Given this list of marker genes RASGRF2, VCPIP1, GEMIN2, E2F2, RASSF3, TRIM71, NT5DC1 (NCBI Gene Id 84571), CHTF8, MAP3K10, TMEM135, RREB1, FBXO42, SLC26A6, RASGRF1, FBXW4, PLEKHM3, RAP1A, FIBP, ZSWIM4, CBLL1, MAP3K11, SLC6A17, MAP3K13, REST, FAM169BP (family with sequence similarity 169 member B, pseudogene), NHSL3, NCAN, MFSD13A, GTF3C3, BTG2, IER3IP1, RORA, DUS1L, TTC7A, DPH2, JADE2, MAPRE2, NCOR2, FAM118A, GGA2, DTX4, AMIGO2, RPL28, SEL1L, TOMM40 (translocase of outer mitochondrial membrane 40), BAG4, EIF2B5, ANKRD50, MKNK2, NHERF4 (NCBI Gene Id 79849), FRMD5, TMEM168, EIF4EBP1, SEMA4F, PHACTR3, SRF, SPTB, LACTB, KLF13, LRRC8B, ANAPC16, CDR2L, CDH5, MEMO1, MAP3K9, KCTD15, VTCN1, LRRC10B, HIF1AN, ZNRF3, PPP4R3A, PRSS35, LRP4, SLC16A6, PADI2, BCL2L14, TMPRSS13, NCKAP5L, VPS36, NKAPD1, CRB2, DOCK3, SARM1, SCARB1, LBH, HOMEZ, TNFAIP3, RBAK, RETREG3, ZNF691, VPS4B, KCNS3, UBE2G1, USP2, SAMD10, EPO, OLFML2A, ADAM28, GCNT1, NDUFA2, FUT4, RABEP2, KMT5C, ESRRA, UBR7, GALNT14, BAP1, SEC14L2, MXD4, M6PR, RABL6, ITGA8, NECAB3, PCDH7, LIN28A, SLC7A1, TSEN54, LFNG, GOLGA5, RHOQ, RFXANK, SLC37A2, ACER2, RBM7, TBC1D1 (TBC1 domain family member 1), SCN2B, SUN1, NEU1, KIAA0319L, NPL, ZKSCAN5, USP38, C1orf210, RAPGEF5, TMEM132E (transmembrane protein 132E), NRXN1 (neurexin 1), UBN1, SBNO1, SPATA31D4, NBEAL2, PRTG, OSBPL9, EIF1AD, PRRC1, FLVCR2, BAK1, VDR, KHNYN, PPAT, DUSP6, ATXN1, ALPK3, KCTD21, TNFSF4, PAFAH1B1, NIPAL4, TRAF6, ULK3, MBOAT2, UBR2, NR6A1, ZBTB7A, CEP85, ANKRD42, TENT5A, LGI2, IL31, MTF1, ARID3B, TAF9B, KLC2, C6orf47, RAB3D, IL6R, TBC1D16, TLE3, TMEM161B, ETS1, CPSF6, RUFY3, MSRB3, ORC2, TAFAZZIN, SH3TC2 (SH3 domain and tetratricopeptide repeats 2), ATP10D, PCTP, DIS3L2 (NCBI Gene Id 282696), SLC38A9, SOD2, SSTR3, TOR2A, DIP2A, SNX18, ABCC4, RBM20, ABHD3, TMTC2, DYNLT3, RPS6KA1, SEMA4B, MAP6, BMF, BCAN, GPATCH8, INTS7, SEMA4D, ZNF827, CGN (NCBI Gene Id 57530), MAN1B1, PDE7A, HCN3, ENPEP, SYVN1, SCLY, PMM2, IGSF11, HAPLN1, KCNA1, DICER1, CYP24A1, MMP11, SUV39H1, MORC2, SMURF1, GANC, ZNF80, SGPL1, SLC35A4, SPATA31D3, TRIAP1, ACHE, LIN28B, ZNF704, HIC2, MYO18A, KCNIP3, PPIL2, CDK19, MFSD9, KDM4C, FMO2, PI4K2B, MFHAS1, TMEM120B, SLITRK6, LIPA, CDC42SE1, ZFYVE1, SLC39A9, ZSWIM5, GJC1, MFSD14B, PRDM1, LCLAT1, PHF20, CCNJ, QSOX2, SLC25A15, DRAM2, IRF4 (NCBI Gene Id 4592), TRMT5, MAPK12, WARS1, RETREG2, UCK2, TTPA, SERTAD3, SYDE2, PPP1R37, ABHD6, SANBR, PLEKHA8, NIPA1, MCTP2, XKRX, GRB10 (NCBI Gene Id 9769), INO80D, C1orf74, ANKRD33B, IL16, TSNARE1, SH3BP5L, UBE2R2, GARIN2, MAMDC2, MYT1, LYZL6, SLC25A35, BLZF1, ABTB1, CDC37L1, ISCU, ZBTB37, ENPP1, DAAM1, EVA1A, DIRAS1, FREM1, CBFB (core-binding factor subunit beta), BNIP2, CACNB3, ZSWIM6, HINFP, NUP210 (nucleoporin 210), CDC42BPG, RFX3, C19orf38, SLC46A3, PPME1, ZSCAN29, PPP2R5C, TBX4, DHX33, SEMA4C, ZNF543, STARD13, TRIM9, DENND6A, IST1, KCNK10, here is a description of the gene set: from publication Chen Y, Wang X (PMID 31504780) Genes predicted to be targets of miRBase v22 microRNA hsa-miR-125b-5p in miRDB v6.0 with MirTarget v4 prediction scores > 80 (high confidence targets). species: Homo sapiens Human Gene Set: MIR125B_5P